Given this list of marker genes ODF2, ATP6V1D, SYT6, NABP2, SECISBP2L, SEM1, CFAP107, UBL4B, JMJD1C, HSD3B7 (NCBI Gene Id 80270), ZC3H10, ZNF287, RPL10, RPL41, BRIX1, OXNAD1, CNST, FBXO15, GALNT2, BCS1L, WDR54, EIF2S1, FBXO8, FIRRM, STX10, DPH3, SMIM29, HNRNPD, TFB2M (transcription factor B2, mitochondrial), SIX6, CHERP, GPS2 (G protein pathway suppressor 2), SKIL, RAI2, CEP44, SMARCD1, SPAG8 (sperm associated antigen 8), SHANK1, ARMC2, ERCC1, SLC27A1 (NCBI Gene Id 376497), CHST14, KCNJ16, CCDC121, TIMM21, JUN, MRPS10, POLR3GL, BCL11B, COX8A, YBX1, CIPC, PGS1, TCF4, IER2, PAN2, NLGN3, AKR7L, HIF1AN, GPN1, ATG101, CLASP1, PCSK1N, RAD1, PRADC1, AMMECR1L, METTL18, RNF216, RFFL, COX7A2, FIS1, PHTF1, ERF, CCDC148, ATP5MC1, TP53BP1 (NCBI Gene Id 7158), ID1, RIPOR1, METRN, PKP4, CCT7, RRAGB, LINC01973, here is a description of the gene set: Comprehensive identification of all functional elements encoded in the human genome is a fundamental need in biomedical research. Here, we present a comparative analysis of the human, mouse, rat and dog genomes to create a systematic catalogue of common regulatory motifs in promoters and 3' untranslated regions (3' UTRs). The promoter analysis yields 174 candidate motifs, including most previously known transcription-factor binding sites and 105 new motifs. The 3'-UTR analysis yields 106 motifs likely to be involved in post-transcriptional regulation. Nearly one-half are associated with microRNAs (miRNAs), leading to the discovery of many new miRNA genes and their likely target genes. Our results suggest that previous estimates of the number of human miRNA genes were low, and that miRNAs regulate at least 20% of human genes. The overall results provide a systematic view of gene regulation in the human, which will be refined as additional mammalian genomes become available. from publication Xie X, Lu J, Kulbokas EJ, Golub TR, Mootha V, Lindblad-Toh K, Lander ES, Kellis M (PMID 15735639) Genes having at least one occurrence of the highly conserved motif M59 WCTCNATGGY in the regions spanning 4 kb centered on their transcription starting sites. The motif does not match any known transcription factor binding site. Human Gene Set: WCTCNATGGY_UNKNOWN studied in species Homo sapiens